Given this list of marker genes ADA2, DCTD, APOBEC3C, BLOC1S6, GNMT, CDADC1, ENPP4, PNP, APOBEC3G (apolipoprotein B mRNA editing enzyme catalytic subunit 3G), DGUOK, PGM2, APRT (NCBI Gene Id 353), UPP1, MAPDA, HPRT1, XDH, PRTFDC1, NT5E, ADK, ADA, NT5C1A, PTGDR, MTAP, NT5C2, AICDA, CDA (NCBI Gene Id 978), ACP3, ICMT, UPP2, NT5C1B, here is a description of the gene set: species: Homo sapiens The chemical reactions and pathways involving any ribonucleoside, a nucleoside in which purine or pyrimidine base is linked to a ribose (beta-D-ribofuranose) molecule. Human Gene Set: GOBP_RIBONUCLEOSIDE_METABOLIC_PROCESS